Given this list of marker genes INHBA (NCBI Gene Id 3624), ZC3H8, PGLYRP3, CLEC4G, GLI3, STAT5A, FOXP3, SFRP1, RC3H1, ID2, INHA, ERBB2, RAG2, ZC3H12A, LILRB4, RC3H2, PTPN2, IFNB1, IFNA2, IL4R, DTX1, LGALS1 (NCBI Gene Id 3956), ASCL2, HLX, NRARP, TBX21, SHH, MDK, TNFSF4, IFNL1, JAK3, RUNX1, RUNX3, ZBTB7B, CD74, SOCS5, BCL6, IHH, HMGB1, SOCS1, CD69, SLC4A2, SMAD7, CDKN2A, PGLYRP1, TNFSF18, CTLA4, IRF1, ANXA1, MIR30B, FGL2, PRDX2, HMGB3, BMP4, CR1, FBXO7, LAG3, LOXL3, FOXJ1, TMEM131L, IL2, CBFB, MIR21, PGLYRP2 (peptidoglycan recognition protein 2), here is a description of the gene set: Any process that stops, prevents, or reduces the frequency, rate or extent of lymphocyte differentiation. studied in species Homo sapiens Human Gene Set: GOBP_NEGATIVE_REGULATION_OF_LYMPHOCYTE_DIFFERENTIATION